Given this list of marker genes DVL1, APELA, TREX1, PLXNA4, DAND5, PDLIM4, MBD3 (NCBI Gene Id 8931), RYR2, PTPRJ, LOX, FREM2, SOD2, KRAS, FRS2 (NCBI Gene Id 10818), ITGB1, NPPB (natriuretic peptide B), JARID2, LDB3, AKAP6, ANKS6, PRKG1, TSC2 (TSC complex subunit 2), MIR222 (NCBI Gene Id 407007), STIL, FOXH1, CREB1, GREB1L, SGCD, PDGFRA, PPP1R13L, DZIP1, ALPK2, MDM2, UBE4B, NCOA6, TTN, TNNI1 (NCBI Gene Id 7135), PCSK5, DLL4, CDK1, FKBP1A, DNAH5, TBX5, MEF2D, FOLR1, SH3PXD2B, CITED2 (Cbp/p300 interacting transactivator with Glu/Asp rich carboxy-terminal domain 2), HSPB7, HEY2, MIR208A, BMP5, FOXF1, FES, AP2B1, ZMIZ1, PLXND1, ADAMTS19, EGFR, MOSMO, GATA5, PDLIM3, DHX36, COL6A1, SMAD4, VANGL2, CHD7, DNAAF1, CRELD1, ATM (NCBI Gene Id 8068), EGLN1, HAND2, DKK1, ATF2, IRX4, RNF207, MIR873, DLL1, MEGF8, SPRY1, DRC1, JPH2, TGFB1, TNFRSF1B, RB1, MIR548C, PDLIM7, MAP2K1, CASP7, NDRG4 (NCBI Gene Id 65009), EDNRA, IFT52, RHOA, MIR195, PRICKLE1, NEDD4, GATA6, PAX8, LRRC10, GLI2, DLC1, SNAI1, TEK, HNRNPU, IFT20, WNT2, CASP3, SLIT2, TGFB3, MTHFD1, EXT1, CCN1, NODAL, HDAC3, LEFTY1, IFT172, ELN, TIE1, BVES, BORCS8, MTERF4, NOTCH1, YY1, DIPK2A, CALR, PCDHA10, MAML1, NF1, MB, SPRED1, TGFBR2, PPARA, RARA (NCBI Gene Id 5914), GREM1, ACVR1, MAP2K2 (NCBI Gene Id 85511), ZDHHC16, DHRS3, MIR21, TNNT2 (troponin T2, cardiac type), CBY1, ERBB2, ROBO1, APC, RYR1, ID1, POU4F2, MOSPD3, MIR1-1, GLI3, MKS1, CCM2L, POPDC2 (NCBI Gene Id 64091), COL2A1, SMYD4, FBN1, TEAD2, RTN4, ID2, HAS2, RAC1, SMO, SMYD1, SENP2, PDGFRB, SALL1, SCX, KAT2A, CSRP3, TPM1, ABL1, CDKN1B, TRIP11, MIR24-1, CDKL1, ZIC3, GPER1, SOX9, AKAP13, SMAD1, CNTRL (NCBI Gene Id 11064), MIXL1, MIR145, SGCG, CLUAP1, MYOCD, RBM15, KAT2B, MYH10, ITGA3, MEIS1, MYO18B, AHI1, NOTO, FOXN4, ROCK2, SNX17, MAPK11, MGRN1, NPPA, ACADM, GATA3, POFUT1, IFT74, RPGRIP1L, PRKDC, RUNX1, TBX19, NPY2R, ERBB4, MED1, ARRB2, PITX2, ZFPM1, FHL2, LUZP1, SCUBE1, C2CD3, APLN, SGCZ, ABCC9, POU6F1 (NCBI Gene Id 5463), TP53, PTCD2 (NCBI Gene Id 79810), TRAF3IP2, SYNPO2L, OXT, CCNB1, GJA1, ISL1, TERT, EYA1, SMYD2, TGFBR3, ADPRHL1, RAMP2, ROBO2, AXIN2, MIR204 (microRNA 204), GSK3A, STK3, HIF1A, ALDH1A2, MAPK3, NACA, ADAMTS5, ANKRD1, PDE2A, HES1, PTPN11, DSP, TP73, ACVR2B, MYL3, MYBPC3, MYH11, IFT57 (intraflagellar transport 57), WNK1, GPC3, SHC1, BMP2, LMNA, MIR19B1, CC2D2A, FZD7, CRIPTO3, GRK2, OSR1, TBX20, ADAM15, TAB2, C10orf71, CIMAP3, PTCH1, CCDC39, BBS5 (NCBI Gene Id 428), RPS6KA2, WNT3A, FHOD3, LRP2, PDLIM1, NOX4, MSX2, MESP2, DSG2, LMO4, MYLK2, MDM4, RGS4, MIR19A, EEF1AKMT4-ECE2, HEG1, TH, MSC, SEMA3C, IFT140, SGCB, POU5F1, TBXT, NKX2-6, SAV1, SMARCD3, CRKL, NFATC1, PKD1, SMAD7, SLC8A1, MIR509-1, TMEM100, OBSL1 (obscurin like cytoskeletal adaptor 1), BMP10, COL14A1, NAGLU, MYLK3, EFNB2, FGF2, PDGFB, PROX1, WNT5A, OXCT1, MYL2, MIR17HG, PSEN1, GLI1, HEY1, IRX3, FOXC1, GATA4, INSR (insulin receptor), PRICKLE4, STK4, PRMT1, ZFPM2, MKKS, TOMM70, ZFP36L1, CCDC40, JMJD6 (NCBI Gene Id 23210), LEMD2, FLRT2, TAB1, RBM20, KDR, SALL4, IFT122, XIRP2, TBX1, FZD2 (frizzled class receptor 2), FAM114A1, NDST1, MAP2K3, ADAMTS9, CTCF (CCCTC-binding factor), PRDM1, MYL7, TSC1, REST, CDKN1A, STRA6, ARL13B, INHBA, FKRP, CER1, ILK, WNT11, MIR20A, CTNNB1, MAP2K5, HCN4, FZD1, CLDN5, ADGRG6, JUN, GNA11, GYS1, PPP3CB, SOX17, MIR199B, KDM6A, TBC1D32, FLRT3, SIK1, GRHL2, CDC42, CACNA1G, HOPX, ADAMTS6, PI16, CFC1, LBX1, NOG, SIRT6, EFNA1, SLC9A1, DVL2, NPY5R, DCTN5 (NCBI Gene Id 84516), RBP4, ENG, DYNC2H1, CACYBP, KCNJ8, ADAP2, LARGE1, ZMPSTE24, ASB2, POU4F1, S1PR1, PLEC, SMAD3, NRP1, BCOR, SOX4 (SRY-box transcription factor 4), MEF2A, HOXA13, TBX3, RB1CC1, SHH, CXADR, CERT1, EP300, PSKH1, TGFB2, TENM4, FOXP1, PARP2, TCAP, BMPR1A, EDN1, APLNR, IGF1, MMP21, KCNK2, CFC1B, MICAL2, PTEN, IHH, CDH11, ATG5, KCNQ1, MMP2, RGS2, ADM, UTY, PTK2, ZBTB14 (zinc finger and BTB domain containing 14), NKX3-1, NPHP3, NOS3, PRKAR1A, NFATC4, G6PD, PDLIM2, TBX18, MYH7, MIR17, MIB1, DAW1, NPY1R, ACTC1, COL11A1, ERBB3, PARVA, GAA, DNAAF3, RXRB, PCNA, ACACB, FN1, PKD2, VGLL4, HDAC9, TNFRSF1A, FGFR2, GJB6, CALCRL, VEGFB, FGF9, EPOR, SOX11, NEK8, CPLANE2 (ciliogenesis and planar polarity effector complex subunit 2), DNAAF4, DAG1, TGFBR1, DCHS1, MED12, AP1B1, MIR23A, SRF, GJC1, PAK1, POPDC3, SORBS2, SNAI2, FGF19, DUSP6, PPARD, CASP8, MAPK14, NPRL3, MIR590, DNAH11, TBX2, CPE, MAPK1, FGFR1, MESP1, FOXJ1, RIPPLY3, ANK2, HAND1, WNT16, OVOL2, PKP2, SIX1 (NCBI Gene Id 6495), ADRA1A, BICC1, SOS1, HTR2B, TRAF3IP1, COL3A1, ECE1, ALPK3, ACVRL1, VCAM1, FOXL1, CCDC103, LCN10, SUFU (SUFU negative regulator of hedgehog signaling), NIPBL, NKX2-5, ODAD2, EMILIN1, FGF20, MYH6, FGF12 (NCBI Gene Id 2257), GALNT11, ROCK1, BMPR2, RBM24, TNNI3, EOMES, PIM1, FGFRL1, PDLIM5, NTRK3, SMAD2, MIR199A1, CRIPTO, TMED2, FGF8, MEF2C, OLFM1, SKI, BORCS8-MEF2B, SMAD5, TWIST1, EVA1A, NOTCH2, NRP2, MIR133A1, MIR499A, CRIP1, HEYL, NDUFV2, PDCD4, IFT25, EPHB4, PLN, CCM2, MEF2B, MIR200B, SYPL2, PPP3R1, KDM6B, BMP4, COL5A1, NRAP, SOX18, CACNA1C, MBD2, DNAI1, SMG9, ADAMTS1, NRG1, ASXL1, CAV3, NSD2, SLIT3, HEXIM1, NEB, TMEM65, BMP7, RARB, WT1, MATR3, CTDP1, MNAT1, ODAD3, EMP2, TNNC1, SCN5A, BBS7, YAP1, MTOR, SMAD6, HECTD1, SOX6, SFRP2, JAG1, ACTN2, MIR25, ODAD4, ASCL1, COX17, BASP1, CAD (carbamoyl-phosphate synthetase 2, aspartate transcarbamylase, and dihydroorotase), NCKAP1, ARID2, MSX1 (msh homeobox 1), GJA5, VEGFA, SHOX2, WDR11, SETDB2, NEBL, ID3, FGF3, PTK7, FOXC2, SEC24B, KCNJ11, RBPJ, here is a description of the gene set: species: Homo sapiens Human Gene Set: GOBP_HEART_DEVELOPMENT The process whose specific outcome is the progression of the heart over time, from its formation to the mature structure. The heart is a hollow, muscular organ, which, by contracting rhythmically, keeps up the circulation of the blood.